Given this list of marker genes SERPINE1, TM4SF1 (NCBI Gene Id 9004), TNFSF8, CACNA1G, IRAK2, SPTAN1, CBX3, RGCC, PDGFA, HMOX1, SLC4A2, KDM6B, TRIB2, VASH1, RARA, ZNF395, ATP6V0D2 (ATPase H+ transporting V0 subunit d2), TRAF1, CCL4, INHBA, SLC1A6, NEAT1, RAB12 (RAB12, member RAS oncogene family), HIP1R, CD80, CCL2, CCR1, P2RX7, NINJ1, PTPRC, IL6R, SLC25A37, TPT1-AS1, RHOB, MIR3648-1, CORO2A, DYRK1A, NR4A2, CD200, CLMN, HTRA3, ZFP36, GAS7, AQP1, MAMDC2, here is a description of the gene set: Human Gene Set: TAKEDA_TARGETS_OF_NUP98_HOXA9_FUSION_6HR_DN from publication Takeda A, Goolsby C, Yaseen NR (PMID 16818636) Genes down-rgulated in CD34+ hematopoetic cells by expression of NUP98-HOXA9 fusion off a retroviral vector at 6h. NUP98-HOXA9, the chimeric protein resulting from the t(7;11)(p15;p15) chromosomal translocation, is a prototype of several NUP98 fusions that occur in myelodysplastic syndromes and acute myeloid leukemia. We examined its effect on differentiation, proliferation, and gene expression in primary human CD34+ hematopoietic cells. Colony-forming cell (CFC) assays in semisolid medium combined with morphologic examination and flow cytometric immunophenotyping revealed that NUP98-HOXA9 increased the numbers of erythroid precursors and impaired both myeloid and erythroid differentiation. In continuous liquid culture, cells transduced with NUP98-HOXA9 exhibited a biphasic growth curve with initial growth inhibition followed by enhanced long-term proliferation, suggesting an increase in the numbers of primitive self-renewing cells. This was confirmed by a dramatic increase in the numbers of long-term culture-initiating cells, the most primitive hematopoietic cells detectable in vitro. To understand the molecular mechanisms underlying the effects of NUP98-HOXA9 on hematopoietic cell proliferation and differentiation, oligonucleotide microarray analysis was done at several time points over 16 days, starting at 6 hours posttransduction. The early growth suppression was preceded by up-regulation of IFNbeta1 and accompanied by marked up-regulation of IFN-induced genes, peaking at 3 days posttransduction. In contrast, oncogenes such as homeobox transcription factors, FLT3, KIT, and WT1 peaked at 8 days or beyond, coinciding with increased proliferation. In addition, several putative tumor suppressors and genes associated with hematopoietic differentiation were repressed at later time points. These findings provide a comprehensive picture of the changes in proliferation, differentiation, and global gene expression that underlie the leukemic transformation of human hematopoietic cells by NUP98-HOXA9. species: Homo sapiens